Given this list of marker genes Pbrm1, Snapin, Zfp62, Atf1, Atp6ap2, Nfix, Rab9, Ccdc88a, Arfgef1, Arhgap5, Smarca2, Nr3c1, Top2b, Gas1, Rbm39, Zmym6, Pkd2, Slc12a2, Slc25a36, Zfp644 (NCBI Gene Id 68866), Lpar1, Rasa1, Gbp7, Shox2, Ddit3 (DNA-damage inducible transcript 3), Kif16b, Tbk1, Alcam, Ifi203, Gadd45a, Ifi202b, Lmo7, Acvr2a, Lims1, Marcks, Ephb3, Zfp68, Ice1, Amot (angiomotin), Cdh11, Aktip, Zscan26, Atf2, Rnf13, Tulp4 (NCBI Gene Id 78646), Col3a1, Kif5b (NCBI Gene Id 16573), Snai2, Pnrc2, Idi1, Ahr, Paxbp1, Irf1, Sms, here is a description of the gene set: Strongly down-regulated at 2-96 h during differentiation of 3T3-L1 cells (fibroblast) into adipocytes. During cellular differentiation and development, it is recognized that many complex molecular mechanisms as well as precise patterns of differentially expressed genes occur in directing precursor cells toward a given lineage. Using microarray-based technology, we examined gene expression across the course of 3T3-L1 adipocyte differentiation. Total cellular RNA was isolated at times 0, 2, 8, 16, 24, 48, and 96 h following treatment with either standard hormonal inducers of differentiation; insulin, dexamethasone, isobutylmethylxanthine (IDX), or IDX plus trichostatin A (TsA), a histone deacetylase inhibitor and potent adipogenic inhibitor. cRNA was synthesized from cellular RNA and hybridized to high density Affymetrix MG_U74Av2 microarray gene chips containing 12,488 cDNA/Expressed Sequence Tags (ESTs) probe sets. From the IDX-only treated cells, all probe sets that were either unchanged or differentially expressed less than 2-fold throughout differentiation with respect to time 0 preadipocytes were excluded from further analyses. This selection resulted in a net of 1686 transcripts, 859 were increased in expression, and 827 were decreased in expression at least 2-fold across differentiation. To focus in on genes that were more specific to differentiation, the same analysis was performed on IDX plus TsA-treated non-differentiating cells and all probe sets from the IDX-only group that exhibited similar expression profiles in the non-differentiating TsA-treated group were excluded leaving a total of 1016 transcripts that were regulated only under differentiating conditions. Six hundred and thirty-six of these transcripts were elevated at least 2-fold and 380 exhibited a decrease in expression relative to time 0 preadipocytes. This group of genes was further analyzed using hierarchical clustering and self-organizing maps and resulted in the identification of numerous genes not previously known to be regulated during adipocyte differentiation. Many of these genes may well represent novel adipogenic mediators and markers of adipogenesis. from publication Burton GR, Nagarajan R, Peterson CA, McGehee RE Jr (PMID 15033539) species: Mus musculus Mouse Gene Set: BURTON_ADIPOGENESIS_11